The following is a description of a gene set: An increased concentration of all types of amino acid in the urine. Human Gene Set: HP_GENERALIZED_AMINOACIDURIA species: Homo sapiens Generalized aminoaciduria, and this is the list of marker genes: DGUOK, SLC34A1, CYP27B1, CYP2R1, CTNS, SLC2A2, ETFDH, NGLY1, GATM (NCBI Gene Id 65211), EHHADH, FAH, ETFB (electron transfer flavoprotein subunit beta), ETFA, NDUFAF6 (NCBI Gene Id 137682)